The following is a description of a gene set: Human Gene Set: GOBP_MANNOSYLATION studied in species Homo sapiens The covalent attachment of a mannose residue to a substrate molecule., and this is the list of marker genes: DOLK, DPM1, B4GAT1, TMTC3, TMTC4, FKTN, TMEM260, CRPPA, POMGNT2, TMTC2, POMGNT1, LARGE2, RXYLT1, POMT2, POMT1, TMTC1, DPM3, LARGE1, NUS1, FKRP